Given this list of marker genes CHRM1, PLD1, DLGAP4, CHRNA10, CHRNA9, KCNB1, CHRNA5, BRSK1, GPR151, CHRNB4, DLGAP3, NEFL, CHRM2, here is a description of the gene set: species: Homo sapiens Human Gene Set: GOCC_CHOLINERGIC_SYNAPSE A synapse that uses acetylcholine as a neurotransmitter.